Given this list of marker genes CLDN4, GNG4, CCN2, VEGFA, BNIP3, SPARC, TNFSF10, ENO2, CCND1, BHLHE40, F3, SLC16A3, PSG1, MAF (MAF bZIP transcription factor), GAL3ST1, GBE1 (NCBI Gene Id 2632), here is a description of the gene set: Upregulation of hypoxia-inducible factors HIF-1 and HIF-2 is frequent in human cancers and may result from tissue hypoxia or genetic mechanisms, in particular the inactivation of the von Hippel-Lindau (VHL) tumour suppressor gene (TSG). Tumours with VHL inactivation are highly vascular, but it is unclear to what extent HIF-dependent and HIF-independent mechanisms account for pVHL tumour suppressor activity. As the identification of novel pVHL targets might provide insights into pVHL tumour suppressor activity, we performed gene expression microarray analysis in VHL-wild-type and VHL-null renal cell carcinoma (RCC) cell lines. We identified 30 differentially regulated pVHL targets (26 of which were 'novel') and the results of microarray analysis were confirmed in all 11 novel targets further analysed by real-time RT-PCR or Western blotting. Furthermore, nine of 11 targets were dysregulated in the majority of a series of primary clear cell RCC with VHL inactivation. Three of the nine targets had been identified previously as candidate TSGs (DOC-2/DAB2, CDKN1C and SPARC) and all were upregulated by wild-type pVHL. The significance for pVHL function of two further genes upregulated by wild-type pVHL was initially unclear, but re-expression of GNG4 (G protein gamma-4 subunit/guanine nucleotide-binding protein-4) and MLC2 (myosin light chain) in a RCC cell line suppressed tumour cell growth. pVHL regulation of CDKN1C, SPARC and GNG4 was not mimicked by hypoxia, whereas for six of 11 novel targets analysed (including DOC-2/DAB2 and MLC2) the effects of pVHL inactivation and hypoxia were similar. For GPR56 there was evidence of a tissue-specific hypoxia response. Such a phenomenon might, in part, explain organ-specific tumorigenesis in VHL disease. These provide insights into mechanisms of pVHL tumour suppressor function and identify novel hypoxia-responsive targets that might be implicated in tumorigenesis in both VHL disease and in other cancers with HIF upregulation. Human Gene Set: MAINA_VHL_TARGETS_DN studied in species Homo sapiens from publication Maina EN, Morris MR, Zatyka M, Raval RR, Banks RE, Richards FM, Johnson CM, Maher ER (PMID 15824735) Genes down-regulated in RCC4 cells (renal cell carcinoma) engineered to stably express VHL off a plasmid vector.